The following is a description of a gene set: studied in species Homo sapiens Genes in the cancer module 333. Human Gene Set: MODULE_333, and this is the list of marker genes: ALDH1B1, AZGP1, KHK, CELSR2, HLA-DRB4, UQCC2, NDUFAF3, GPD1, ZC3H3, SOD1, CFI, PLEKHB2, NOS1, ASB16, MIF4GD, RMDN3, EPHX2, GCSH, CHCHD6, ACP2, HMGN2, ABCA7, ATP7B, YTHDF2, TRPM1, IGF1, MIS18A, CRY1, ZNF559